Given this list of marker genes POLG, H2AZ1, SRSF2, PNN, SRSF4, RPL21, HDAC1 (NCBI Gene Id 3065), SNRPE, CDC123, SRSF9, SNRPF, CSNK2B, SNRPA, HNRNPA1, SET, ATP5PB, DHX9 (NCBI Gene Id 3450), EIF4A1, ESD, RPL10A, HMGN1, RPL27, EEF2, RPL19, PSMB2, HNRNPU, ATP5F1C, TRA2B, EPRS1, PCBP2, DDX39B, POLR2G, NONO, PFN1, RPL14, SUMO2, GDI2, RPS5, CCT4, YWHAZ, CLIC1, RPL29, TCP1, EEF1G, NACA, EIF3F, SLBP, MCM3, NCL, PSMA1, NDUFA12 (NADH:ubiquinone oxidoreductase subunit A12), BCLAF1, IK (NCBI Gene Id 3550), NASP, SNRPA1, PPIA, RPL17, HPRT1, CAPRIN1, RPS23, PSMA5, HNRNPM, SRSF3, PTMA, DHPS, PWP1, SNRPD2, BLMH, CCT7, NAP1L1, YWHAQ, ZNHIT3, PSMD8, PSME1, FXR1, RHOA, ACTG1, MCM6, RPS19, RPS8, RPL6, MAZ, CBFB, ERH, DUT (deoxyuridine triphosphatase), KHDRBS1, CFL1, SLC25A3, SNRPD3, NPM1, CAPZA1, RPL18, PPP1CC, RACK1 (NCBI Gene Id 90938), HNRNPD, TRIM28, PCBP1, EEF1B2, POLR2K, RAD21, PRMT1, ILF2, LMNB2, TAF9, RPL7, COPS5, H3-3A, TIAL1, EIF4B, SLC25A6, ATP5F1B, RPS7, RPS24, APEX1, here is a description of the gene set: Human Gene Set: GCM_APEX1 Neighborhood of APEX1 studied in species Homo sapiens Neighborhood of APEX1 APEX nuclease (multifunctional DNA repair enzyme) 1 in the GCM expression compendium